The following is a description of a gene set: Human Gene Set: GOMF_N_ACETYLLACTOSAMINIDE_BETA_1_3_N_ACETYLGLUCOSAMINYLTRANSFERASE_ACTIVITY species: Homo sapiens Catalysis of the reaction: a beta-D-galactosyl-(1->4)-N-acetyl-beta-D-glucosaminyl derivative + UDP-N-acetyl-alpha-D-glucosamine = an N-acetyl-beta-D-glucosaminyl-(1->3)-beta-D-galactosyl-(1->4)-N-acetyl-beta-D-glucosaminyl derivative + H+ + UDP., and this is the list of marker genes: B3GNT4, B4GAT1, B3GNT3, B3GNT2, B3GNT7